Given this list of marker genes PLXNB1, RND1, MYH10, RHOA, RHOB, MYH11, ROCK1, MYL6, RHOC, SEMA4D, ARHGEF12, MYL12B, LIMK2, MYH14, ROCK2, MYH9, LIMK1, ERBB2, MYL9, ARHGEF11, here is a description of the gene set: Sema4D-mediated attraction of endothelial cells requires Rho, but not R-Ras, signaling. Sema4D-mediated plexinB1 activation activates Rho and its downstream effector ROCK. ROCK then phosphorylates MLC to induce actomyosin stress fiber contraction and to direct the assembly of focal adhesion complexes and integrin-mediated adhesion. studied in species Homo sapiens part of: Sema4D in semaphorin signaling Reactome Pathway: Sema4D induced cell migration and growth-cone collapse